The following is a description of a gene set: Human Gene Set: MIR6878_5P Genes predicted to be targets of miRBase v22 microRNA hsa-miR-6878-5p in miRDB v6.0 with MirTarget v4 prediction scores > 80 (high confidence targets). species: Homo sapiens from publication Chen Y, Wang X (PMID 31504780), and this is the list of marker genes: GABPB1, NEDD9, RPRD1B, SF3A3, PCDHA13, MAN2A1 (mannosidase alpha class 2A member 1), NCOA2, INSL5, MYOCD, PRR23A, ZNF800, SLC8A3 (solute carrier family 8 member A3), IQGAP3, PELI1, CTCF, CELF3, MYRF, NIPSNAP3B, ARL4A, PCDHAC2, TNFAIP8L2, TMTC3, SP1 (Sp1 transcription factor), AKAP6, STAM2, STRN, ABHD2, SUMF2, WNT1, NAMPT, CORO1C, STX11, SIAE, AAK1 (NCBI Gene Id 652453), EZH1, RASSF8, PCDHA1, STARD9, ATP13A3, USB1, UBQLN4, BOLA2-SMG1P6, SMIM21, GAGE1, ZNF225, RAB6D, OSBP2, NFAT5, EBF3, GRIN3A, WDCP, IMPG2, SHISA7, XPR1, PCDHA3, DIS3, NOTCH2, MPZL1, INO80D, VWA5A, ADAM19, DNAAF8, CTNND2, TRAM2, CXCL17, BAZ2A, MDGA2, RNF39, SEPTIN10, MTSS1, PSG1, CHPF, EGFR, BVES, GPATCH2, TIGAR, DCLK1, SERPINA9, PTPN9, PCDHAC1, NEBL, CHORDC1, MTCH2, HIP1, CTNNA1, PRPF40A, FAM117A, SMAD2, MPPED2, CD34, PCDHA10, ST3GAL2, FRMPD3, HS3ST3A1, ATP7B, YIPF6, ZNF275, SLC20A2, SLC1A2, ZNF391, SEPTIN8, PCDHA11 (NCBI Gene Id 56138), NFYC, SNPH, FBXL7, GOLPH3L, POU3F2, CDK15, SLC16A2, GRIK5, POGZ, PCDHA6, TESPA1, FRMPD4, DDX6, SEC31B, PRR23C, LILRB4, TOB2, GAREM1, PDPN, SLC8A1 (NCBI Gene Id 6546), CLTA, SYT6, CALN1, TBCEL, DCAF12, MAK16, PSG4, KLF12, VGLL3, PCDHA2, BPTF, CNTN5, SCN3A, UMAD1, PCDHA12, PBX1, UBASH3B, SESN2 (NCBI Gene Id 83667), CSTB, FZD7, RABEP1 (rabaptin, RAB GTPase binding effector protein 1), SYT14, GABARAPL1, ATP1B2, TSHZ3, PCDHA5, RAB6C, KHSRP, MAX, SEMA4G, MXD1, ZCCHC14, SPRY4, PPHLN1, CTNND1, NEDD4L, PRSS27, TMTC1, SRRM4, ATG16L2, ABCC4, DMP1, ICOSLG, PGPEP1, B3GLCT, NECTIN1, GAGE12D, BTG1, GASK1A, KDM5B, KCNH4, E2F2, TBC1D8B, PCSK1, ZNF605, PGBD2, HS3ST3B1, NIPSNAP3A, NETO2, MARCKSL1 (MARCKS like 1), CNOT4, NCCRP1, ZCWPW1, LURAP1L, LARP1, ZFHX3, NAV1, GIGYF1, PIKFYVE, GCC1, GNGT2, PRRT2, ZNF19, ODAD1, PCDHA7, WDR33 (WD repeat domain 33), FOXL2NB, MYEOV, HYCC1, SDF2, MITF, ARPC2, FABP4, PCDHA4, SLC17A8, TP53INP2, PTPRC, PCDHA9, KIF3C, FRMD4A, DAB2, TCAF2, FOXL2, PHF24 (PHD finger protein 24), ERMAP, HNRNPL, PAK1, DDB1, GPR158 (G protein-coupled receptor 158)